Given this list of marker genes HIF1AN, VEGFC, HEY1, HIF1A, MIR148A, VEGFA, VEGFB, MIR31, HES1, here is a description of the gene set: MicroRNA for targeting cancer growth and vascularization in glioblastoma Human Gene Set: WP_MICRORNA_FOR_TARGETING_CANCER_GROWTH_AND_VASCULARIZATION_IN_GLIOBLASTOMA species: Homo sapiens